Given this list of marker genes H2-Q10, Topors, Ighv1-53, Ighv2-4, Ighv8-9, Ighv1-42, Ighv1-24, Ighv1-56, H2-M10.3, H2-DMb2, H2-M10.4, Ighv2-2, Ighv10-3, Trav7n-5, Jchain, Ighv1-5, 2410137M14Rik, H2-Ob, H2-Aa, Ighv7-1, Igha, H2-DMb1, Trav14-1, Ighv8-4 (NCBI Gene Id 629919), Ighv1-75, Ighv3-5, H2-Ab1, Ighv1-71, Ighg2c, Ighv2-7, Fcnb, Ighv1-47, Slc7a9, Cd1d2, Ighv5-17, Ighv6-6, Ighv8-13, Cd40, Ighv1-66, Trav14d-3-dv8, H2-Eb1, Ighv2-6, Ighv1-63, Ighv1-43, Ighv1-54, Tgfb1, Ighv8-11, Ighv3-8, Ighv5-12, Ighv1-58, Ighv1-64, H2-Q2, Trav14n-1, Ighv11-1, Sirpa, Ighv1-31, Ighv1-77, Ighv8-6, Trav7-5, Ighm, Ppp2ca, Itga4, Klrd1, Igll1, H2-T13, Tspan4, Spon2, Klrh1, Ighv1-84, Trav7-4 (T cell receptor alpha variable 7-4), Ighv1-39 (NCBI Gene Id 780891), H2-DMa, Ighv5-6, Ighv9-3 (immunoglobulin heavy variable V9-3), Tapbp, Ighv1-76, Trav7-2, Ighv6-3, Tap2, Ighv8-5, Iglc1, H2-Q6, Iglc3, Ighv8-2, Trav14-3, Ighv1-50, Ighv3-1, Fcna (ficolin A), Abo (ABO, alpha 1-3-N-acetylgalactosaminyltransferase and alpha 1-3-galactosyltransferase), H2-M10.5, Trav7-6, Ighv1-16, Fcgrt, Ighv2-3, Ighv2-5, Ighv4-1, Ighv1-67, Ighv14-2, H2-T10, Ighv1-12, H2-M2, Trav7-3, Ighg1, Hnrnpm, H2-M5, Ighv14-1, Maml1, Ighg3, Ighv11-2, Tap1, Ighv3-6, Ighv8-12, Trav19, Ighv10-1, Ighv1-62-3, H2-Q1, Gp2, Ighv8-8, Ighv1-80, Ighv1-61, Trav7-1, H2-T5, H2-Q7, Lck, B2m, H2-M9, Ighv7-3, H2-M10.1, Ep300, Ighv14-3, Ighv1-4, H2-K1, Trav14n-2, Ighv1-55, Ighv2-6-8, Ep400, Ighv9-1, Ighv5-4, Trav7n-4, Klrc2, Ighv13-2, Ighv1-11, H2-Q4, H2-D1, Ighv14-4, Ighv5-9, Ighv5-12-4, Ighv12-3, Ighv5-16, Iglc2, Ighv6-7, Ighd, Ighv2-9-1, Ighv3-3, H2-M10.2, Ighv1-15, H2-Eb2, Ighv3-4, Ighv9-2, Ppp2r1a, Trav15-2-dv6-2, H2-Ea, H2-Oa, Ighv2-9, Ighv1-7, H2-T22, Ighv1-81, Ighv1-49, H2-T23, Cd1d1, Ighv6-5, Ighg2b, Ighv16-1, Ighe, Ighv1-23, Psap, Ighv9-4, Trbv1, Ighv1-26, Trbv29, H2-M10.6, Ighv1-85, Dhcr24, H2-M3, Ighv1-22, H2-T3, Ighv1-82, Trav14-2, Ighv1-34, H2-M11, Plg (NCBI Gene Id 18815), Trav23, Ighv6-4, Ighv1-72, Trav7d-4, Ighv1-78 (immunoglobulin heavy variable 1-78, NCBI Gene Id 213570), H2-M1, H2-T24, Trav7d-6, Trav14n-3, H2-T15, here is a description of the gene set: Binding to an antigen, any substance which is capable of inducing a specific immune response and of reacting with the products of that response, the specific antibody or specifically sensitized T-lymphocytes, or both. Binding may counteract the biological activity of the antigen. Antigen binding by an MHC protein complex allows the antigen to be displayed to a T cell or NK cell. species: Mus musculus Mouse Gene Set: GOMF_ANTIGEN_BINDING